Given this list of marker genes SIAH1, SLC39A14, SOWAHC, DIPK1A, SGCE, SERINC5, HEATR1, HLA-DQA1, SLC23A2, FRY, IGSF3, TOP1, DNMBP, ATP6V0A2, BCL7A, PEG10, KIAA0040, ELMO1, PNMA2, IRF4, IGHD, ATOX1, ARMCX2, SIT1 (signaling threshold regulating transmembrane adaptor 1), TMEM140, GSDME, ZFP64, IGKV1D-17, MYBL2, KANK2, TRRAP, DIP2C, CEACAM1, MFAP1, BNIP3L, OAS2, ST6GALNAC4, WSB2, FBXW11, FCER2, SEPTIN10 (NCBI Gene Id 151011), AZIN1, RRBP1, OAS1, PIM1, DMD, ABCA6, AGPAT5, GPR18, CPT1A, TLR7, CREB3L2, AKAP12, FLNB, NSF, JADE3, TBC1D1, BACH2, CYP51A1, LPL, CCR7, KLK2, ST6GAL1, BCL10, here is a description of the gene set: Human Gene Set: BILBAN_B_CLL_LPL_UP species: Homo sapiens Genes up-regulated in B-CLL (B-cell chronic leukemia) samples expressing high levels of LPL compared with those expressing low levels of the gene. from publication Bilban M, Heintel D, Scharl T, Woelfel T, Auer MM, Porpaczy E, Kainz B, Kröber A, Carey VJ, Shehata M, Zielinski C, Pickl W, Stilgenbauer S, Gaiger A, Wagner O, Jäger U, German CLL Study Group (PMID 16617321) Lipoprotein lipase (LPL) is a prognostic marker in B-cell chronic lymphocytic leukemia (B-CLL) related to immunoglobulin V(H) gene (IgV(H))mutational status. We determined gene expression profiles using Affymetrix U133A GeneChips in two groups of B-CLLs selected for either high ('LPL+', n=10) or low ('LPL-', n=10) LPL mRNA expression. Selected genes were verified by real-time PCR in an extended patient cohort (n=42). A total of genes discriminated LPL+ from LPL- B-CLLs. Of these, the top three genes associated with time to first treatment were Septin10, DMD and Gravin (P</=0.01). The relationship of LPL+ and LPL- B-CLL gene expression signatures to 52 tissues was statistically analyzed. The LPL+ B-CLL expression signature, represented by genes was significantly related to fat, muscle and PB dendritic cells (P<0.001). Exploration of microarray data to define functional alterations related to the biology of LPL+ CLL identified two functional modules, fatty acid degradation and MTA3 signaling, as being altered with higher statistical significance. Our data show that LPL+ B-CLL cells have not only acquired gene expression changes in fat and muscle-associated genes but also in functional pathways related to fatty acid degradation and signaling which may ultimately influence CLL biology and clinical outcome.